Given this list of marker genes PPP1R26, SLC16A8, FUT7, SLC17A7, CDH7, here is a description of the gene set: Human Gene Set: MIKKELSEN_IPS_LCP_WITH_H3K4ME3_AND_H3K27ME3 from publication Mikkelsen TS, Hanna J, Zhang X, Ku M, Wernig M, Schorderet P, Bernstein BE, Jaenisch R, Lander ES, Meissner A (PMID 18509334) Somatic cells can be reprogrammed to a pluripotent state through the ectopic expression of defined transcription factors. Understanding the mechanism and kinetics of this transformation may shed light on the nature of developmental potency and suggest strategies with improved efficiency or safety. Here we report an integrative genomic analysis of reprogramming of mouse fibroblasts and B lymphocytes. Lineage-committed cells show a complex response to the ectopic expression involving induction of genes downstream of individual reprogramming factors. Fully reprogrammed cells show gene expression and epigenetic states that are highly similar to embryonic stem cells. In contrast, stable partially reprogrammed cell lines show reactivation of a distinctive subset of stem-cell-related genes, incomplete repression of lineage-specifying transcription factors, and DNA hypermethylation at pluripotency-related loci. These observations suggest that some cells may become trapped in partially reprogrammed states owing to incomplete repression of transcription factors, and that DNA de-methylation is an inefficient step in the transition to pluripotency. We demonstrate that RNA inhibition of transcription factors can facilitate reprogramming, and that treatment with DNA methyltransferase inhibitors can improve the overall efficiency of the reprogramming process. Genes with low-CpG-density promoters (LCP) bearing the bivalent tri-methylation marks at H3K4 (H3K4me3) and H3K27 (H3K27me3) in MCV8.1 cells (induced pluripotent cells, iPS). studied in species Mus musculus